The following is a description of a gene set: from publication Plasari G, Calabrese A, Dusserre Y, Gronostajski RM, McNair A, Michalik L, Mermod N (PMID 19752192) studied in species Mus musculus Transforming growth factor beta (TGF-beta) and platelet-derived growth factor A (PDGFAlpha) play a central role in tissue morphogenesis and repair, but their interplay remain poorly understood. The nuclear factor I C (NFI-C) transcription factor has been implicated in TGF-beta signaling, extracellular matrix deposition, and skin appendage pathologies, but a potential role in skin morphogenesis or healing had not been assessed. To evaluate this possibility, we performed a global gene expression analysis in NFI-C(-/-) and wild-type embryonic primary murine fibroblasts. This indicated that NFI-C acts mostly to repress gene expression in response to TGF-beta1. Misregulated genes were prominently overrepresented by regulators of connective tissue inflammation and repair. In vivo skin healing revealed a faster inflammatory stage and wound closure in NFI-C(-/-) mice. Expression of PDGFA and PDGF-receptor alpha were increased in wounds of NFI-C(-/-) mice, explaining the early recruitment of macrophages and fibroblasts. Differentiation of fibroblasts to contractile myofibroblasts was also elevated, providing a rationale for faster wound closure. Taken together with the role of TGF-beta in myofibroblast differentiation, our results imply a central role of NFI-C in the interplay of the two signaling pathways and in regulation of the progression of tissue regeneration. Mouse Gene Set: PLASARI_TGFB1_SIGNALING_VIA_NFIC_1HR_UP Genes up-regulated after 1 h of TGFB1 stimulation in MEF cells (embryonic fibroblast) with NFIC knockout vs wild type MEFs., and this is the list of marker genes: Ccr5, Pdgfra, Soat1, Ifitm6, AW551984, Insig1, Nr4a2 (nuclear receptor subfamily 4, group A, member 2), Meox1, Flt1, Mir142hg, Kcnn4, Zfhx3, Mfap4, Car6, Rpl39l, Pdp1, Kcnab1, Evi2a, Ahr, Rbp1, AI504432, Idi1, Enpep, Foxg1, Calcrl, Tent5c, Il2rg, Rab39b, Cyp51, Oxct1, Ephb2, Gsdme, Fli1, Tatdn2, Ctla2a (NCBI Gene Id 13024), Ctla2b, Dse, Ccn3